The following is a description of a gene set: A transcription coregulator activity that represses or decreases the transcription of specific gene sets via binding to a DNA-binding transcription factor at a specific genomic locus, either on its own or as part of a complex. Corepressors often act by altering chromatin structure and modifications. For example, one class of transcription corepressors modifies chromatin structure through covalent modification of histones. A second class remodels the conformation of chromatin in an ATP-dependent fashion. A third class modulates interactions of DNA-bound DNA-binding transcription factors with other transcription coregulators. studied in species Mus musculus Mouse Gene Set: GOMF_TRANSCRIPTION_COREPRESSOR_ACTIVITY, and this is the list of marker genes: Ccnd1, Tle4, Bcorl1, Runx1t1, Ark2n, Noc2l, Ctbp2, Btg2, Sap30, Rcor1, Hnrnpu, Fhl2, Trim28, Mier1, Tob1, Riox2 (NCBI Gene Id 78649), Ezh2, Sirt1, Snw1, Parp10, Uri1, Tob2, Wtip, Rcor3, Yap1, Asah1, Drap1, Bcl11a, Hif1an, Dhrs7b, Nr0b1, Ajuba, Zfp354b, Crebbp, Sdr16c5, C1d, Eno1, Hdac4, Lcor, Eid1, Mybbp1a, Hdac9, Rcor2, Parp14, Ezh1, Wnt4, Nr0b2, Casp8ap2, C1qbp, Npat, Hdac3, Basp1, Tbl1x, Hsbp1 (NCBI Gene Id 68196), Cmtm2a, Smarca4, Smyd1, Tfap2a (transcription factor AP-2, alpha, NCBI Gene Id 21418), Tcerg1 (NCBI Gene Id 76839), Hdgf, Mier2, Yaf2, Mta3, Hmgb1, Kdm5b, Ruvbl2, Irf2bpl, Dnajb1, Rybp, Trib3, Sin3a, Ddx54, Gmnn, Dnmt3b, Gps2, Mta2, Ski, Zfpm1, Tle3, Sap18, Hdac1 (histone deacetylase 1), Trerf1, Zmynd11, Tle5, Zfpm2, Chd4 (chromodomain helicase DNA binding protein 4), Hsbp1l1, Med1, Pa2g4, Tcp10c, Tcf25, Mier3 (MIER family member 3), Hipk2, Pex14, Prmt5, Zmynd8, Cdyl2, Id3, Irf2bp2, Ddit3, Pbxip1, Foxp3, Mecp2, Lmo4, Mta1, Map3k10 (mitogen-activated protein kinase kinase kinase 10), Brd7, Kctd15, Ctbp1, Ncor1, Tbl1xr1, N4bp2l2, Cbfa2t3, Insm2, Zfp541, Nrip1, Tcp10b, Zfp366, Hdac7, Sfmbt2, Hmga2, Pias4, Kctd1, Ncor2, Jazf1, Phf24, Cnot7, Phf12, Hipk1, Cdyl, Phb1, Rbbp8, Bcl3, Tle7, Smad7, Parp9 (poly (ADP-ribose) polymerase family, member 9), Id4, Mlip, Crym, Nipbl, Kdm1a, Hspa1a, Daxx, Nsd1, Yeats2, Sin3b, Eid2, Cys1, Ankrd1, Eno1b, Wwtr1, Bhlhe41 (NCBI Gene Id 79362), Id2, Zbtb32, Sfmbt1, Tcp10a, Rbfox2, Mideas, Eid2b, Tle2, Tle1 (NCBI Gene Id 320837), Zfp653, Elane, Hdac5, Cbfa2t2, Uxt, Hr, Atf7ip, Cops2, Flywch1, Sirt6, Hipk3, Prdm8 (NCBI Gene Id 77630), Rere, Bend6, Bcor, Ccar1, Limd1, Cited2, Cir1, Setd5, Irf2bp1, Atn1, Tsg101, Tle6, Arid5a, Lmcd1, Spen, Prkn, Zfp451, Tcf4, Dmap1, Kmt5a, Scai, Pias1, Id1, Gon4l (gon-4 like)